The following is a description of a gene set: Human Gene Set: GOBP_RETINAL_CONE_CELL_DIFFERENTIATION The process in which a relatively unspecialized cell acquires the specialized features of a retinal cone cell. studied in species Homo sapiens, and this is the list of marker genes: BBS10, HCN1, NOTCH1, THRB, THY1, GNAT2, USH1C, GNAT1, RP1, CRB2, RORB, PDE6C, DIO3, CABP4